Given this list of marker genes DUSP10, MIR181C, ID2, NOG, NR1D1, TREM2, DRD3, NF1, F2, DLX1, NTRK3 (NCBI Gene Id 4916), DLX2, GPR37L1, ID4 (inhibitor of DNA binding 4), NKX6-2, DAAM2, HES5, LDLR (NCBI Gene Id 3949), NOTCH1, HMGA2, NKX6-1, DAB1, NR2E1, MYCN, HES1 (NCBI Gene Id 3280), LIN28A, TMEM98, CTNNB1, MIR181B1, here is a description of the gene set: Human Gene Set: GOBP_NEGATIVE_REGULATION_OF_GLIAL_CELL_DIFFERENTIATION Any process that stops, prevents, or reduces the frequency, rate or extent of glia cell differentiation. studied in species Homo sapiens